The following is a description of a gene set: studied in species Homo sapiens Human Gene Set: GOBP_REGULATION_OF_CARTILAGE_DEVELOPMENT Any process that modulates the rate, frequency, or extent of cartilage development, the process whose specific outcome is the progression of the cartilage over time, from its formation to the mature structure. Cartilage is a connective tissue dominated by extracellular matrix containing collagen type II and large amounts of proteoglycan, particularly chondroitin sulfate., and this is the list of marker genes: AXIN2, HOXA11, BMP6, TGFB1, SMAD7, SCIN, RARG (retinoic acid receptor gamma), PTH, BMPR2, CCN1, POR (NCBI Gene Id 96440), RFLNB, SOX9, MIR21, WNT5A, PKDCC, FGF18, TRPS1, WNT9A, TGFB2, SOX6, PRKG2, GDF6, MBOAT2, IHH, LOXL2, EFEMP1, ADAMTS7, GDF5, MAF, GLG1, NOG, NR5A2, CTNNB1, MDK, LNPK (lunapark, ER junction formation factor), SCX, CCN2, RARB, NKX3-2, ZNF219, CTSK, RARA, CCN4, FRZB, TGFBR1, BMP10, CHADL, PTPN11, BMP1, MUSTN1, WNT11, LTBP3, RUNX2, GREM1, BMP4, ZBTB16, SOX5, ACVRL1, SIX2, GLI3, PTHLH, SHOX2, TAPT1, SNAI2, KAT2A, LEP, BMP2, ADAMTS12, SMPD3, SMAD3, BMPR1B, SMAD1, RFLNA, GDF2